The following is a description of a gene set: studied in species Homo sapiens Any deviation from the normal amount of a metabolite in urine. Human Gene Set: HP_ABNORMAL_URINE_METABOLITE_LEVEL Abnormal urine metabolite level, and this is the list of marker genes: COL4A5, CTLA4, BICC1, MT-ATP6, MARS1, GLYCTK, TCN2, CLPB, REN, CASR, KIRREL1, TNFRSF11B, KIF1B, SLC34A1, HMGCS2, RNU7-1 (NCBI Gene Id 100147744), COL4A4, SGSH, FBXL4, OSGEP, TFAM, AGXT, PEX14, TP53RK, PIK3C2A, COX16, ARSB, FKRP, ACADS, DBH, SLC22A12 (solute carrier family 22 member 12), SLC28A1, EMP2, PHKA2 (phosphorylase kinase regulatory subunit alpha 2), IDUA, KARS1, FAH, CACNA1S, GSS, ETS1, IDH2, TPRKB, GALT, RMRP (NCBI Gene Id 6023), TBC1D8B, AMMECR1, FDFT1, SH2B1, UROS, SLC35C1, PEX1, SDHC, GCDH, BUD23, POLG, GUSB, C4A, IL1RN, TANGO2, SPRY2, CPT2, OPLAH, PRODH, ARG1, GANAB, PGK1, SARDH, PHKB, PRDX1 (NCBI Gene Id 5052), MT-ND6, GALE, TNFAIP3, DLD, ELN, ANLN, PHKG1, COL2A1, C3, PAX4, MCCC1, PHKG2, ATPAF2, MAGI2, LMNB2, PLOD2, ATP5MK, C1GALT1C1, MTRR, AMN, TBC1D24, HADHA, DAAM2, SLC7A7, UBE2L3, ACSF3, SUGCT, CR2, XPC, AUH, GRHPR, MT-TS2, HNF4A, MYH9, ABCC8, SLC16A1, WDR73, SERAC1, MIA3, NFU1, COQ4, OGDH, FOCAD, BAZ1B, PDX1, ASPH, NPR2, TNIP1, NDUFAF6, MEFV, LCAT, MED12, SLC13A3, NPHS1, IL10, MVK, DNASE1, SNAP29, ACVR1B, PKD1, MYCN, TBL2, TRPC6, APRT, PDCD1, HNF1A, SCO1, PYGL, EXT2, TAT, TMEM270, UROC1, VIPAS39, PCCA, MOCS2, SLC22A5, MAX, GTF2I, GTF2IRD2, PREPL, ACTN4, HAL, RET, STAT2, CUBN, FLT1, C4B, HGD, GLB1, MICOS13, ERCC4, MMADHC, AASS, GEMIN4 (gem nuclear organelle associated protein 4), SPP1, GLA, CASK, CD320, NGLY1, SLCO1B1, TAMM41, SLC5A1, MT-TN, SUMF1, ADSL, SLC37A4 (NCBI Gene Id 84965), OCRL, SDHD, MLIP, PEX5, PUS3, LMNA, NPHP3, PEPD, PSTPIP1, YRDC, APPL1, ERCC3, MT-TQ, TRIM8, COX14, COL6A1, LDHA, FMO3 (flavin containing dimethylaniline monoxygenase 3), GCLC, FOXP2, ACSL4, HPRT1, G6PD, CD81, PMM2, DGUOK, IRF1, UNC45A, TPK1 (thiamin pyrophosphokinase 1), DDOST, SLC6A19, ANKFY1, SGCB, LETM1, CLTRN, XDH (NCBI Gene Id 7498), FH, HLA-DPA1, DGKE, SLCO1B3, CLDN16, ATP7B, EHHADH, PIGA, SAA1, NEUROD1, PLOD1, KLF6, ZAP70, SNX14, PIGB, KIAA0319L, STOX1, MCEE, PAH, NEU1, ARHGDIA, ATP5F1E, MCCC2, CLIP2, MT-CO2, ACADSB, WDR4, DNASE1L3, ALAD, PYGM, STX1A, GK, MT-ATP8, DNASE2, CORIN, VPS50, MMUT, GALNS, RYR1, PHYKPL, NFS1, HMGCL, TAFAZZIN, PCBD1, MOCOS, INF2, TRPV6, NT5C3A (NCBI Gene Id 96002), CRPPA, SLC1A1, OXCT1, KIF23 (NCBI Gene Id 981), ETFB, ETFA, NDUFS4, LRPPRC, RFC2, GTF2IRD1, MT-CO1, SLC26A1, VHL (von Hippel-Lindau tumor suppressor), BCKDHA, IL1B, SLC2A9, SLC3A1, DNMT3A, NUP85, ALDH5A1, ERCC5 (ERCC excision repair 5, endonuclease), L2HGDH, GYS2, DDB2, PBX1, SDHB, ARHGAP24, PHOX2B, SFXN4, GATA3, PFKM, SLC6A20, TMEM127, CLCNKA, DPYD, GAPVD1, CEL, TKT (transketolase), KCNE5, SLC12A3, FKBP6, GAMT, DPYS, METTL27, ADA2, NUP133, PIEZO1, THBD, GATA6, PRTN3, FGFR2, LMBRD1, MAN2B1, UQCRB, TP53 (NCBI Gene Id 7157), NIPBL, DNAJB11 (DnaJ heat shock protein family (Hsp40) member B11), GNE, RRM2B, LIPT1, PRPS1, IER3IP1, VPS37D, TNFRSF11A, LAGE3, GLUD1, KRAS, GBA1, TRNT1, HADH, COA8, ASL, OBSCN, TLR7, ALG9, HTRA2, MT-ND4, HACE1, NUP205, PDSS2, LPIN1, MTR, PIK3CA, FUCA1, PGAM2, ACADVL, GCK, APOA1, CD46, DPH1, SDHA, CAD, EPAS1, KCNJ1, PNP, COQ6, SLC6A18, GNPTG, SLC25A11, CYP27A1, SLC25A1, DKC1, MMAB (metabolism of cobalamin associated B), SGPL1, MAF, ALG5, D2HGDH, EIF4H, PCK1 (NCBI Gene Id 5105), GALK1, CYP2R1, MECP2, CPT1A, AGA, IFT140, DLST, PIGT, INS, WDR19 (WD repeat domain 19), SLC36A2, SKIC3, XPA, AGXT2, NUP93, ISCU, ACAT1, PEX12, APOE, SLC19A2, ATP5F1D, FN1, TRMU, LIN28B, APOL1, JAZF1, DNAJC30, PAX2, FOXC2, MMAA, SUOX, SLC2A2, NUP107, DMD, NF1, STAT3, CBS, SLC25A21, FARS2, SLC6A8, COL4A6, CD59, FCGR2B, CTNS (cystinosin, lysosomal cystine transporter), IDS, IDH1, CYP27B1, DMGDH, SMARCAL1, AGK, GPHN, MUTYH, IVD, CAMKMT, ATP5F1A, PTPN22, GLDC (glycine decarboxylase), PHKA1, GNS, KLF11, MT-TF, FCGR3B, CPOX, KANK2, COQ8B, WT1, UMPS, MDH2, BSND, STK11, IGHG1, GNPTAB, ALDOB, TIMM50, CASP10, NDUFB10, SURF1, NPHS2, FAN1, ABCD4, MT-ND1, HELLPAR, CCND1, PPM1B, CFH, UMOD (NCBI Gene Id 7369), SLC6A2, CLCN5, IRAK1, ACAD8, HLCS, CA5A, SLC25A20, APC, RPIA, CPS1, NADK2, ACP5, SEC61A1, CFB, ETFDH, ERBB2, CD2AP, TMEM70, NOTCH2, PPOX, HEXB, LRP2, CLCNKB, GUCY2D, TREX1, ACADM (acyl-CoA dehydrogenase medium chain), MAFB, BLK, NCF1, UROD, SAT1 (spermidine/spermine N1-acetyltransferase 1), ALDOA, ATAD3A, ANO5, ADAMTS13, ERCC8, COQ2, LMX1B, SLC25A15, OTC (NCBI Gene Id 5009), MLYCD, DDC, VPS33B, MMACHC, KYNU, SLCO2A1, STAT4, TNFSF4, GON7, PET100, ECHS1, TK2, TDO2, LMO1, HMBS, GSN, UPB1, ERCC6 (NCBI Gene Id 282965), TRMT5, DCXR, NAGA, HSPD1, GGT1, ACAD9, LAMB2, VPS33A, OXGR1, MRPL39, FTCD, HGSNAT, MT-TL1, NAGLU, KHK, HPD, CTH, CRB2, GCH1, DHTKD1, SLC16A12, IRF5 (NCBI Gene Id 84729), SLC18A2, ETHE1, MYO1E, SDHAF2, ALDH6A1, ITGA8, SLC52A1, PKD2, ARSK, PTPRO, SLC25A13, FBP1, HMOX1, COL4A3, SUCLG1 (NCBI Gene Id 8802), ITGA3, CHUK, CFI, FDX2, SLC5A2, HSD17B10, G6PC1, MTX2, ALDH4A1, BANK1, SPINK5, MANBA, ITGAM, HNF1B, PCCB, NOS1AP (nitric oxide synthase 1 adaptor protein), ATIC, ASS1, ATP6V1B2, ERCC2, DNAJC19, PXK, FGA, SLC7A9, SLC35A1, GAA, MT-ND5, ALK, IFT172, IBA57, ALPL, BCS1L, MT-CO3, MT-TH, MT-TW (NCBI Gene Id 4578), HADHB, SCARB2, NUP160, HLA-DRB1, HLA-DPB1, TRPV4, LYZ (NCBI Gene Id 4069), HCFC1, GATA1, ASPA, MOCS1, LPIN2, KRT18, MTHFR, KCNJ11, OPA3, OAT, NOS3, NUP37, HIBCH, CYC1, SHPK, PLCE1, SUCLA2, SLC12A1 (NCBI Gene Id 6557), OFD1, SARS2, SMAD4, GATM, NSMCE2, LIMK1